Given this list of marker genes ABCC9, FGFR2, NPR2, NEK1, PTH1R, PDE4D, ADAMTS10, RAB33B, MMP2, FBN1, IFT56, CANT1, FGFR1, here is a description of the gene set: Broad metatarsal species: Homo sapiens Human Gene Set: HP_BROAD_METATARSAL Increased side-to-side width of a metatarsal bone.